The following is a description of a gene set: Abnormality in the space in the meninges beneath the arachnoid membrane and above the pia mater that contains the cerebrospinal fluid. species: Homo sapiens Human Gene Set: HP_ABNORMAL_SUBARACHNOID_SPACE_MORPHOLOGY Abnormal subarachnoid space morphology, and this is the list of marker genes: MPDU1, NARS1, OTUD7A, ADA2, GDF2 (NCBI Gene Id 51423), ALG12, MT-ND1, GRIN1, LMNB2, MT-TL1, MAT2A, PRKG1, MT-CO1, GP1BA, SNRPN, GP1BB, MAN2C1, MT-CO2, MT-ND6, WAC, THSD4, KIFBP, TSEN2, GCDH, MTRR, PLPBP, ENG, PIGW, IFT56, MT-TS2, TGFBR2, PIGA, MYH11, STIM1, ZFX, F10 (NCBI Gene Id 14058), WARS2, IDH1, ATP11A, SMAD3, ANGPTL6, ALG9, ALG11, L1CAM, TGFBR3, CD109 (NCBI Gene Id 135228), AHCY, AIFM1, MT-TH, CUX1, SEPSECS, MRE11, DTYMK, ALG2, TGFB3, RASA1, MT-TF, COX16, LOX, MT-TW, SMAD2, ACTA2, TSEN15, ELN, SMAD4, MYLK, TGFB2 (transforming growth factor beta 2), GAA, TSEN34, THSD1, PLCH1, CHD3, ITGB3, HEY2, DCC, MT-ND4, RNU4ATAC, ALDH7A1, FOXE3, MFAP5, APP, SLC33A1, COL3A1 (collagen type III alpha 1 chain), CDH2, SYNGAP1, TSEN54, DOCK8, NMNAT1, TGFBR1, DNM1, ITGA2B, ACVRL1, FBN1, ITGA2, MT-ND5, MT-TQ, MT-CO3